The following is a description of a gene set: Human Gene Set: GOCC_BLOOD_MICROPARTICLE studied in species Homo sapiens A phospholipid microvesicle that is derived from any of several cell types, such as platelets, blood cells, endothelial cells, or others, and contains membrane receptors as well as other proteins characteristic of the parental cell. Microparticles are heterogeneous in size, and are characterized as microvesicles free of nucleic acids., and this is the list of marker genes: FGA, IGLV1-47, IGHV3-13, HRG, HPR, CIB2, TF, STOM (NCBI Gene Id 2040), SDCBP, HSPA7, F2, C1S, ITIH2, INTS11, C3, C4BPA, CFHR1, C8G, C8A, C1QC, CFB, AMBP, SERPINA3 (NCBI Gene Id 95022), IGKV3-15, KDM4D, CP (NCBI Gene Id 1356), HSPA6, ANXA5, JCHAIN, IGHA1, IGKV1-39, IGHA2, ZNF177, HBD, ORM1 (NCBI Gene Id 5004), HBA2, IGLC2, C4A, IGHD, HBE1, PON1, ITIH1, TMPRSS13, HSPA1B, ACSM1, HBG2, FGG, HSPA1L, A2M, IGKC, APOL1, PRSS1, C1QB, CLU, POTEF, HSPA8, MSN, SLC4A1, CPN2, GC, ACTA1, IGLV3-25, IGHV3-7, BCHE, IGHG3, AHSG, ZBTB38, KNG1, FN1, SERPINC1, VTN, DNPEP, ITGA2B, IGKV1D-12, EIF2A, A1BG, ACTG2, IGHG4, IGKV4-1, YWHAZ, ACTG1, MIR19B1, APOA1, AGT, ORM2, CFH, IGHG1, POTEE, IGKV1-17, IGHM, PZP, HSPA2, SERPING1 (serpin family G member 1), FGB, APCS, SERPINF2, HP, IGKV1-5, FCN2, GSN, C1R, MIR503, PLG, C1RL, ACTC1, TFRC (NCBI Gene Id 7037), IGHV3-23, ITIH4, PROS1, CD5L, TGFB1, ENG, HBA1, HPX, IGLV3-21, C4B, APOA4, HSPA1A, IGLC1, APOE, APOA2, OAZ3, IGKV1D-33, ANGPTL4, HBB, AFM, PFN1, KRT1, GRIPAP1, SLC2A1, FCN3, C9, CLIC1, F13A1 (NCBI Gene Id 2162), ZNF559-ZNF177, LGALS3BP, PSMC5, ACTB, IGKV2-30, IGHG2, IGKV2D-28, IGKV3-20 (NCBI Gene Id 647478), CFHR3, IGLC3, ALB